Given this list of marker genes PTGS2, ALOX5, here is a description of the gene set: part of: Biosynthesis of specialized proresolving mediators (SPMs) Reactome Pathway: Biosynthesis of electrophilic ω-3 PUFA oxo-derivatives species: Homo sapiens Electrophilic oxo-derivatives of ω-3 polyunsaturated fatty acids (ω-3 PUFAs) are generated in macrophages and neutrophils in response to inflammation and oxidative stress to promote the resolution of inflammation. Being electrophilic, these derivatives reversibly bind to nucleophilic residues on target proteins (thiolates of cysteines and amino groups of histidine and lysine), triggering the activation of cytoprotective pathways. These include the Nrf2 antioxidant response, the heat shock response and the peroxisome proliferator activated receptor γ (PPARγ) and suppressing the NF-κB proinflammatory pathway. Thus, these electrophilic derivatives transduce anti-inflammatory actions rather than suppress the production of pro-inflammatory arachidonic acid metabolites. An oxo-derivative of EPA has been shown to ablate leukemia stem cells in mice, which may represent a novel chemoprotective action for some oxo-derivatives. In humans, dietary supplementation with ω-3 PUFAs has been reported to increase the formation of oxo-derivatives. The enzymes cyclooxygenases (COX), lipoxygenases (LOs) and cytochromes P450s, acting alone or in concerted transcellular biosynthesis, initially form epoxy or hydroxy intermediates of ω-3 PUFAs docosahexaenoic acid (DHA), docosapentaenoic acid (DPAn-3) and eicosapentaenoic acid (EPA) before these are further oxidised to electrophilic α,β-unsaturated keto-derivatives by cellular dehydrogenases.